The following is a description of a gene set: from publication Schaefer CF, Anthony K, Krupa S, Buchoff J, Day M, Hannay T, Buetow KH (PMID 18832364) JNK signaling in the CD4+ TCR pathway studied in species Homo sapiens Human Gene Set: PID_TCR_JNK_PATHWAY, and this is the list of marker genes: LAT, CRKL, PRKCB, MAP3K1, CRK, MAP4K1, GRAP2, LCP2 (lymphocyte cytosolic protein 2), MAP3K8, JUN, DBNL, MAP2K4, MAP3K7, MAPK8